The following is a description of a gene set: species: Mus musculus Mouse Gene Set: GOBP_MAMMARY_GLAND_DUCT_MORPHOGENESIS The process in which anatomical structures of the mammary ducts are generated and organized. Mammary ducts are epithelial tubes that transport milk., and this is the list of marker genes: Wnt4, Pml, Epha2, Msx2, Mst1, Slc12a2 (NCBI Gene Id 20496), Pgr, Etv4, Med1, Phb2, Tbx3, Cav3, Pthlh, Lrp6, Ddr1, Ncoa3, Kdm5b, Tgfb1, Slit2, Fgfr2, Wnt5a, Gli2, Robo1, Sostdc1, Lrp5, Csf1, Csmd1, Ar, Scrib (NCBI Gene Id 54559), Fgf10, Esr1, Btrc, Ccl11, Etv5, Tfap2c, Nr3c1, Ptch1, Ntn1, Src, Areg, Perp (PERP, TP53 apoptosis effector), Vdr